Given this list of marker genes Ago4, Tarbp2, here is a description of the gene set: electronically inferred by orthology from the curated human pathway studied in species Mus musculus This event has been computationally inferred from an event that has been demonstrated in another species.<p>The inference is based on the homology mapping from PANTHER. Briefly, reactions for which all involved PhysicalEntities (in input, output and catalyst) have a mapped orthologue/paralogue (for complexes at least 75% of components must have a mapping) are inferred to the other species. Reactome Pathway: Small interfering RNA (siRNA) biogenesis part of: Gene Silencing by RNA